Given this list of marker genes Ins2, Jchain (immunoglobulin joining chain), Insr, Rps19, Ins1, Camk1d, Lbp, Clec7a, here is a description of the gene set: Mouse Gene Set: GOBP_POSITIVE_REGULATION_OF_RESPIRATORY_BURST Any process that increases the rate frequency or extent of a phase of elevated metabolic activity, during which oxygen consumption increases; this leads to the production, by an NADH dependent system, of hydrogen peroxide (H2O2), superoxide anions and hydroxyl radicals. studied in species Mus musculus